The following is a description of a gene set: Mixed hypo- and hyperpigmentation of the skin species: Homo sapiens Human Gene Set: HP_MIXED_HYPO_AND_HYPERPIGMENTATION_OF_THE_SKIN, and this is the list of marker genes: PCNT, UBE2A (NCBI Gene Id 7319), LMNA, KRT5 (NCBI Gene Id 3852), PSENEN, KRT14 (keratin 14), DPP9, PIGN, POGLUT1, SASH1, POFUT1, ADAR, SMS